Given this list of marker genes HMCN2, MYOT, GFRA3, PTK7, EPHB1 (NCBI Gene Id 2047), EPHB3, ROBO1, L1CAM, EPHA7, ROBO2, EPHB2 (NCBI Gene Id 50980), here is a description of the gene set: Human Gene Set: GOMF_AXON_GUIDANCE_RECEPTOR_ACTIVITY Combining with an extracellular messenger and transmitting the signal from one side of the membrane to the other to results in a change in cellular activity involved in axon guidance. studied in species Homo sapiens